The following is a description of a gene set: Human Gene Set: HP_ABNORMAL_LEUKOCYTE_COUNT Number of leukocytes per volume of blood beyond normal limits. studied in species Homo sapiens Abnormal leukocyte count, and this is the list of marker genes: LBR, MPLKIP, RPL15, MS4A1 (membrane spanning 4-domains A1), SEC61A1, PTPRC, SPRED2, PACS2, RIPK1, CYP27B1, CTPS1 (CTP synthase 1), RFXAP, FOCAD, ITGAM, VPS45, BRAF, SKIC3, GATA1, CD79A, RPS26, BACH2, SRP19, RPL26, MTHFD1, AARS1, BRCA2, CYBC1, ATP6AP1, FANCM, EOGT (NCBI Gene Id 79580), DEF6, FOXN1, LYST, SLC39A7, TNFRSF13C, HELLS, ERCC4, FANCC, IL7, RPL18 (ribosomal protein L18), STAT6 (signal transducer and activator of transcription 6), NSMCE3, ZBTB16, RPS24, NABP1, ACAT1, PALB2, TREX1, TFRC (transferrin receptor), IVNS1ABP, RAD51C, FUT8, FBXW7, G6PC3, PI4KA, TNFAIP3, MTRR, TNFRSF13B, RARA, MTR, DIAPH1, ORAI1, ANAPC1, SLC30A7, IL6R, NAE1 (NCBI Gene Id 8883), HYOU1, DCLRE1B, STK4, LMBRD1, RPS27, RMRP, WDR1, PSMB10, SLC37A4, SASH3, MPL, BRIP1, MMAB, LYN (NCBI Gene Id 4067), EPB42, HSCB, BLM, RPL8, FANCE, EPG5, IGHG1, TCN2, ETV6, IKZF3, ATM, TICAM1, TRPV6, FCHO1, RBM8A (NCBI Gene Id 9939), STAT2, SBDS, FIBP, CR2, LIG1, TBX21, JAK1, CTNNBL1, SF3B1, POLD1, TTC7A, RAD51, FCGR3B, TCIRG1, AGR2, RPS19, ZNFX1, RUNX1, SPINK1, RPS28, IKZF1, RAC2, FOXP3, SAT1, PRSS1, MECOM, MVK, POMP, MMUT, FANCB, LMNB2, FMO3, OAS1, ALG12, PTPN6, CUBN, CD247, SOCS1, ICOSLG, MICU1, AK2, IRF8, ZNF699, PRIM1, PSMB9, XRCC2, CAPN3, HBB, C1GALT1C1, NOTCH1, ACP5, FNIP1, ITGB2, BLK, DOCK8, CCBE1, STAT5B, RELB, PKHD1, FBXL4, SRP68 (NCBI Gene Id 96239), WAS, ASXL1, GINS1, LEP, TLR7, RPL35A, NFKB2, RFXANK, IL2RA, TNFSF12, ITK, PDGFRA, TRAF3, JAK2, GFI1, CSF3R, TBK1, UNC13D, MMACHC, MYSM1, KMT2D, DOCK2 (dedicator of cytokinesis 2), RPS14, FANCL, CARD10, TNFRSF9, UROS, ATP6AP2, MDM4, LPIN2, TBL1XR1, SALL4, SREBF1, CD81, AP3B1, AP3D1, SMARCAL1, PCCA, CD3E, USP48, ZAP70, CA2, SAMD9L, LCP2 (NCBI Gene Id 3937), MAP2K1, RNF113A, NAF1, NRAS, NPM1, DNMT3B, SHARPIN, PPIL1, GATA2, NLRP1, NHEJ1, CTRC, PXK, DOCK6, STAT4, IKBKG, CASP10, IL2RB, LIPA, RPS15A, SLC19A1, STAT1, IGHM, IL7R, SARS2, RPS7 (ribosomal protein S7), KNSTRN (NCBI Gene Id 90417), CHD7, ELANE, ZBTB24, TDP2, ERCC2, EIF2AK3, TAFAZZIN, MMAA, RPL5, SKIC2, ZPR1, BANK1, TP53, FDX2, PRSS2, ARPC1B, TFR2, ERCC6L2, PRKAR1A, MYD88, CASK, NCAPG2, SLC35C1, CD79B, RFX5, RPL31, DOCK11, CTLA4, CIITA, PGM3, XRCC4, RHOH, ARPC5, RRAS2, SAMD9, NR3C1, JAK3, TSR2, CDCA7, SLC46A1, CALR, JAZF1, TONSL, LAT, NUMA1, SGPL1, CLPB, CORO1A, IGLL1, TPP2, COG4, PIK3CD, CYP2R1, DDX41, RNU4ATAC, NHLRC2, RASGRP1, TINF2, FCGR2A, RFWD3, ATP11A, TNIP1, CD40LG, NFKBIA, IL10, STIM1, FAT4, SPINK5, CBLB, ZNF341, PLCG2, TRAC, PNP, OSTM1, SH2D1A, PRKCD, TNFSF4, RPL35, BRCA1, CD8A, HEATR3, CAMK2B, ABCD4, CD40, LACC1, UNC93B1, SYK, LCK, NDUFA6, SLF2, FANCF, FASLG, MCM10, FCGR2B, PRF1, IFIH1 (NCBI Gene Id 64135), RPL27, PTEN, DKC1, IL6ST, STING1, PCCB, MAGT1, PRDX1, RBPJ, STAT3 (NCBI Gene Id 6774), CDSN, RNASEH2B, RPS29, CXCR2, ADH5, TLR3, GTF2H5, KDM6A (lysine demethylase 6A), CPA1, TRNT1, FERMT3, TNFRSF1B, STN1, SCO2, SPI1, G6PD, PIGA, DNAJC21, PRKDC, AP1S3, CASP8, CDC40, FANCG, CARD9, MSN, OTULIN, DLL4, AMN, WIPF1 (WAS/WASL interacting protein family member 1), CARS1, RPS10, SLC7A7, VPS33A, C4A, ATRX, SP110, KRAS, IRF5, TGFB1, SLX4, TNFRSF1A, ABL1, TCF3, FANCA, ADA2, TARS1, ARHGEF1, KIT, MALT1, ARHGAP31, IRAK1, LRRC8A, AGA, CASR, MAP3K14, IL1RN, ANKRD26, PIK3CG, ERCC3, CD4, UNC119, RPA1, MEFV, SMARCD2, IRAK4, IL37, UHRF1, CD3G, CD3D, NBN, SCARB2, LIG4, ELF4, RPL11, GSS, NOP10, NLRP3, ISCU, RECQL4, THPO, OTUD5, IFNG, NCKAP1L, ITCH, REL (REL proto-oncogene, NF-kB subunit), UBE2A, RAB27A, ADAMTS3, FIP1L1, BCL10, HAX1, HLA-DPB1 (NCBI Gene Id 3115), HMGCL, LEPR, IFNGR1, IL36RN, NFKB1, BLOC1S6, IKBKB, DCLRE1C (NCBI Gene Id 64421, DNA cross-link repair 1C), SLC27A4, IPO8, LAMTOR2, UBE2L3, LRBA, RAG2, CBL, BTK, PIK3R1, TBX2, PDCD1, CEBPE, TBXAS1, BCL11B, BCR, C4B, RPS20, CD19, JAGN1, UBE2T, FANCI, RPL9, CRELD1, TET2, USB1, IRF2BP2, SRSF2, TERC (NCBI Gene Id 7012), GALE, BLNK, PTPN22, SH2B3, RAP1B, SLC35A1, ICOS, BTNL2, MAD2L2, B2M, TLR8, CDH23, BCOR, EFL1, TOM1, PSMB4, RNF31, RAG1, ETS1, IL21, XIAP, TERT, SRP54, MECP2, CARD11, RTEL1 (regulator of telomere elongation helicase 1), CD28, SPP1, STXBP2, IVD, STX11, HLA-DRB1, RBCK1, FANCD2 (NCBI Gene Id 2177), MYC, PML, KIAA0319L, CFTR, GBA1, EXTL3, GTF2E2, TTI2, IL2RG, ADA, CXCR4, FAS, IRF1, HTRA2, VPS13B, USP8, NLRP12, POLD3 (DNA polymerase delta 3, accessory subunit), DNASE1, RPS17